The following is a description of a gene set: Human Gene Set: GOBP_REGULATION_OF_BLOOD_BRAIN_BARRIER_PERMEABILITY species: Homo sapiens Any process that modulates blood-brain barrier permeability, the quality of the blood-brain barrier that allows for a controlled passage of substances (e.g. macromolecules, small molecules, ions) into and out of the brain., and this is the list of marker genes: TJP3 (tight junction protein 3), TJP2, ABCC8, OCLN, SH3GL2, VEGFA, TJP1, ZEB2, ANGPT1